Given this list of marker genes NKAP, MAP3K5, CERK, ARPC5L, TIMM22, MARS1, TMEM131 (NCBI Gene Id 55369), PCMTD1, AURKA, GSTT2 (glutathione S-transferase theta 2 (gene/pseudogene)), NPEPPS, PARP3 (NCBI Gene Id 25908), PIK3CG, MTOR, GTSE1, PKIG, FANCL, CD38 (NCBI Gene Id 952), EXO1, PPM1E, GMEB2, UBASH3A, ZNF483, ATG16L2, SLC16A1, NUP93, RAB3IP (NCBI Gene Id 64325), DNAJB11, HMGCLL1, MYBPC2, CKAP2, PTGR1, F13A1, PARPBP, DNAJC21 (DnaJ heat shock protein family (Hsp40) member C21), EZH2, SPAG5, MAN2A1, FBXL12, UBE2H, ZNF706, CSRP2, CENPE, C19orf38, PIK3C2A (phosphatidylinositol-4-phosphate 3-kinase catalytic subunit type 2 alpha), IRF5, ADAM19, DESI1 (NCBI Gene Id 91610), TMEM121, PCLAF, CSK, LMO4, TPST1, ARL5A, RBMXL1, HERPUD1, ACP3 (NCBI Gene Id 55), TSPAN13, COQ7, MBD2, TNFRSF13C, LY86, TREM1, IGHM, SPEF2, PSMC1, ETS1, TTLL11, FZD9, CENPS, C6orf118, MROH2A, CDKN2C, NUDT15, KNSTRN, BTG2, ACP1, MEGF9 (multiple EGF like domains 9), GGA2, KIAA0930, GPAT3, PTTG1, TNFAIP3, FAM50A, RPL3L, ZBTB2, COA6, ANKRD40, PNP, GFM1 (NCBI Gene Id 85476), GEMIN6, DMTF1, NUP37, GFRA2, HVCN1, NUF2, BMAL1, MRPL51, EIF4A3, TMEM263, CCNA2, TCF19, SNN, VAV2, ATG101, BRD9, SBK1, JCHAIN, CAPSL, KARS1, AP1AR, CASS4, KRAS, RBM27, EXOSC9, NXT1, BCAT1, PAFAH1B3, TACC3, SHB, KLHDC4, CCDC38, HIVEP3, SLC7A6OS, NDC80, CDK2AP2, PHF2, RSPH9, FRG1 (NCBI Gene Id 2483), PDS5B, ELFN1, TTPAL, ITGB1BP1, THEMIS2, CYTIP, RXFP1, RAB8A, SPC25, MAGI3, DOK3, NDE1, RNASE4, TXNDC16, SLC15A3, LY6E (NCBI Gene Id 7999), TDP1, SNX25, BUB1B, NSMCE1, UBE2C, ZNF821, GAS2L3 (growth arrest specific 2 like 3), SMC4, LITAF, ENDOD1, CDKN1A, LY9, DPP4, RAD51C, CDC25B, TMEM132E, RASGRP2, RRAGD, TK1, CMC2, UBE2D3, NCAPH, MKI67, AUTS2, SUPT16H, PPIH, CD79B, ALDH1B1 (NCBI Gene Id 219), SEC13, TRIM11, ACY3, CTSC, RFLNB, SMARCB1, GPR18, SLAMF7, BIN1, LRCH1, MINDY2, TYMS, EIF2AK3, SDC4, IFT22, ENPP6, CEACAM21, RCSD1, IGKC, GPSM2, SH3BP5, DLGAP5, PREP, TMCC1, CYB561A3, KPNA1, here is a description of the gene set: Genes up-regulated in periperal blood monocytes (PBMC): tolerant kidney transplants versus healthy controls. Human Gene Set: GSE22229_RENAL_TRANSPLANT_VS_HEALTHY_PBMC_UP studied in species Homo sapiens In this study, investigators recruited the largest reported cohort of tolerant kidney transplant recipients who maintained their graft after ceasing to take their immunosuppression drug, and compared this cohort to subjects with stable allograft function while on immunosuppression and healthy non transplated, controls. Using gene expression studies, they identified genetic markers that are strong candidates for predicting kidney transplant candidates who may benefit from minimization or withdrawl of immunosuppression. Microarrays were used to detect expressed gene profiles of whole-blood total RNA from subjects in the tolerant, standard immunotherapy and healthy control participants from publication Newell KA, Asare A, Kirk AD, Gisler TD, Bourcier K, Suthanthiran M, Burlingham WJ, Marks WH, Sanz I, Lechler RI, Hernandez-Fuentes MP, Turka LA, Seyfert-Margolis VL, Immune Tolerance Network ST507 Study Group (PMID 20501946)